The following is a description of a gene set: The directed movement of fatty acids into, out of or within a cell, or between cells, by means of some agent such as a transporter or pore. Fatty acids are aliphatic monocarboxylic acids liberated from naturally occurring fats and oils by hydrolysis. studied in species Homo sapiens Human Gene Set: GOBP_FATTY_ACID_TRANSPORT, and this is the list of marker genes: SLC22A2, AKT2, P2RX7, ACE, SLC22A9, DRD2, ACSL5, P2RX4, RBP2, RBP1, FABP6, ABCD4, SLC22A11, OXT, RBP5, TNFRSF11A, THBS1, PLA2G2D, CPT1B, OC90, NOS2, UCP2, SLC22A8, PLA2G4F, SLCO2B1, SLCO3A1, IRS2, ABCD3, FABP2, FABP7, EDN1, PLA2G4A (phospholipase A2 group IVA), PTGES, NMB (NCBI Gene Id 4828), SLC27A5, SLC2A1, LYN, ACSL4, ANXA1, PLA2G5, FABP3 (fatty acid binding protein 3), PLA2G2E, DRD4, PROCA1, CPT2, CRABP2, SLCO4A1, PLA2G2A, SLCO2A1, PLA2G3, KCNJ8, CYP4F2, FABP4, ACSL1, NTSR1, PMP2, PLA2G10, SLC22A6, SLC22A1, CRABP1, SYK, CROT, PLA2G12B (phospholipase A2 group XIIB), EPRS1, PPARG, SLC5A8, PPARA, SLC27A1, ACSL3, ERFE, MFSD2A, ABCD2, ABCD1, PNPLA8, CYP4A11, GOT2, PLA2G2F, FABP9, FABP1, SLC43A3, TNFSF11, FABP5, REPIN1, SLC27A3, CD36, SLC27A6, SLC27A2, SPX, PTGS2, DRD3, AVPR1B, SLCO1B1, PLA2G1B, PLA2R1, NMUR2, FABP12, MIF, LYPLA1, CPT1A, PLIN2, SLC25A17, SLC22A7, SLC25A20, SLC27A4, PPARD, PLA2G2C, IL1B (NCBI Gene Id 3553), BDKRB2, RBP7, TMEM135 (transmembrane protein 135), RPS6KB1, FABP5P3 (NCBI Gene Id 378208), PLA2G12A, LEP, ABCC4, APOE, FIS1, AKT1